The following is a description of a gene set: The region of a condensed chromosome that includes the centromere and associated proteins, including the kinetochore. In monocentric chromosomes, this region corresponds to a single area of the chromosome, whereas in holocentric chromosomes, it is evenly distributed along the chromosome. Mouse Gene Set: GOCC_CONDENSED_CHROMOSOME_CENTROMERIC_REGION studied in species Mus musculus, and this is the list of marker genes: Fbxo28, Dctn2, Pbrm1 (polybromo 1), Pafah1b1, Nde1, Seh1l, Sycp2, Arid2, Dctn5, Ska1, Brd7, Bod1, Meikin, Dctn1, Atrx, Plk5, Chmp4c, Cebpb, Psen2, Aurkb, Chmp2a, Dynlt3, Cenpc1, Rangap1, Cenpt, Cenpq (centromere protein Q), Trappc12 (trafficking protein particle complex 12), Dync1i1, Dynll1, Ska3, Phf6, Ccnb1-ps, Anapc16, Aurka, Spag5, Kat8, Xpo1, Sgo2b, Orc2, Cenpl, Ppp1r12a, Cenpk, Smarce1, Nup160, Cenpv, Fbxw11, Ndel1, Pmf1, Ppp1cc, Cfdp1, Bub1, Chmp7, Rec8, Kif18a, Cenpm, Kat5, Septin6 (septin 6), Mis12, Chmp1b, Septin7, Kmt5c, Arhgap33os, Cenpa, Cenpo (centromere protein O), Dctn3, Chmp6, Nup98, Kntc1 (NCBI Gene Id 208628), Kif2b, Dync1li2, Apc, Plk3, Nup85, Chmp5, Cenpi, Tex14, Cenpp, Chmp3, Smarcd1, Prpf4b, Nuf2, Clasp1, Dync1li1, Cbx5 (chromobox 5), Chmp1b2, Sgo1, Zw10, Plk1, Spdl1, Nup133, Hsf1, Mtcl1, Tpr, Crebbp, Cenps, Cenph, Sgo2a, Cenpe, Smarcc1, Ska2, Septin2, Psen1, Mtbp, Nup37, Smarca4, Csnk1a1, Smarcb1, Rassf2, Plk2, Champ1, Ccnb1, Cenpf, Cenpb, Kif2c, Ahctf1, Birc5, Knstrn, Cenpu, Trp53bp1, Zwint, Lrwd1, Hjurp, Kmt5b, Nek2, Zfp276, Ttk, Ss18l1, Bub1b, Zwilch, Cbx3, Chmp1a, Spc24, Sycp2l, Incenp (NCBI Gene Id 98139), Pinx1, Hnrnpu, Dctn4, Chmp4b, Nup43, Aurkc, Itgb3bp, Gtf2b, H3f3a, Spc25, Dsn1, Meaf6, Cdt1, Firrm, Gpatch11, Cenpx, Sin3a, Ncapd3, Kat2b, Ndc80, Kansl1, Knl1, Dctn6, Smarcd2, Ercc6l, Clasp2 (NCBI Gene Id 97514), Cdc20, Smarcc2, Ncapd2, Nup107, Phf10, Zfp207, Spout1, Sec13, Actl6a, Actl6b, Nsl1, Mad1l1, Sycp3, Cenpn, Bub3, Actb, Nudcd2, Mad2l1, Cenpw, Smc1a, Phf2, Sugt1, Chmp2b, Ncapg, Ckap5